The following is a description of a gene set: from publication Chen Y, Wang X (PMID 31504780) Genes predicted to be targets of miRBase v22 microRNA hsa-miR-520g-5p in miRDB v6.0 with MirTarget v4 prediction scores > 80 (high confidence targets). studied in species Homo sapiens Human Gene Set: MIR520G_5P, and this is the list of marker genes: EGLN3, GNA14, ANK2, MAPK8, PDE1A, IL21, OSBPL6, TMEM117, SORCS1, AP3M2 (NCBI Gene Id 10947), GFM2, NRK, VCF2, KLHL7, TIMELESS, ANTXR1, KCNAB1, PHF3, SS18, GNAQ, FKBP5, MAL2, PLN, EIF2AK1, SMIM17, ERCC4, HNRNPC, MN1, OLFM3, SEC14L1, FBXL2, PTRH1, BCL6B, CIB4, ZNF367, CBX4, URGCP-MRPS24, BTBD7, BRINP3, NELL2, HIPK1, ACSL4, BEND4, SSPN, GIPC3, TJAP1, ENDOU, ZNF566, HSP90AA1, FBXO7, LILRA1, MANEAL, PPP1R9A, MTPN, SHLD1, PMEPA1, PDZK1, OGG1, LAMP2, ENSG00000223438